Given this list of marker genes POLR2A, FUS, PPP1R8, NCBP1, CPSF7, SF3A2, SNRPC, SRSF4, POLR2K, SF3B3, RBM5, PABPN1, CSTF2T, PHF5A, UBB, SRSF2, HNRNPU, PAPOLA, SYMPK, SRSF9, RBMX, CSTF3, SF3B2, UBA52, POLR2D, SNRPD1, SUGP1, CHERP, SF3B1, SNRPA, TUT1, XRN2, FIP1L1, PPP1CA, CPSF2, SRSF1, HTATSF1, CLP1, HNRNPH2, PUF60, HNRNPA2B1, NCBP2, POLR2J, SRSF10, CPSF3, RBM10, SNRPF, POLR2F (RNA polymerase II, I and III subunit F), PCBP1, U2AF1L4, SRRT, DHX9, HNRNPA1, CDC40, PCBP2, SNRNP70, DDX42, POLR2C, CCAR1, PAPOLG, SNRPD2, POLR2L, SNRPB2, WDR33, PPP1CB, PCF11, SRSF6 (NCBI Gene Id 6431), SRSF5, SRSF12, DDX5, TCERG1, HNRNPD, SNRPD3, CSTF2, U2AF1, CPSF1, SNRPB, SRSF8, HNRNPC, HNRNPR, SNRPA1, RBM39, POLR2I, PRPF40A, U2AF2, POLR2G, SRSF11, GTF2F2 (NCBI Gene Id 2963), PPP1R10, HNRNPL (heterogeneous nuclear ribonucleoprotein L), CSTF1, RPS27A, SRSF7, HNRNPH1 (heterogeneous nuclear ribonucleoprotein H1), POLR2H, HNRNPF, NUDT21, RBBP6, GTF2F1, RBM25, SF3A3, SF3B6, SRRM2, DNAJC8, UBC, RBM17, U2SURP, SF3B4, SF3B5, HNRNPA3, SF3A1, CPSF4, HNRNPK, PTBP1, YBX1, POLR2E, HNRNPM, POLR2B, CPSF6, SNRPG, SMNDC1, SRSF3, TRA2B, SNRPE, SNRPN, DDX46, DHX15, here is a description of the gene set: studied in species Homo sapiens Reactome Pathway: mRNA Polyadenylation part of: mRNA 3'-end processing <p>All eukaryotic mRNAs, with the exception of histone mRNAs, undergo a 3' end maturation step consisting of a specific endonucleolytic cleavage of the precursor followed by polyadenylation of the upstream cleavage fragment; the downstream fragment is degraded. In mammalian cells, the pre-mRNA cleavage site is determined by at least four sequence elements. 1) The central and most highly conserved signal is AAUAAA or a close variant located ~20 nucleotides (nt) upstream of the cleavage site. 2) The preferred sequence at the cleavage site is CA. 3) GU- or G-rich downstream elements are important, and 4) sequences upstream of AAUAAA, such as UGUA, can also contribute. The majority of protein-coding genes have multiple polyadenylation sites (PASs) generating either different protein isoforms or mRNA isoforms differing in the lengths of their 3' untranslated regions (UTRs) and consequently in their interaction with RNA-binding proteins and microRNAs. Formation of mRNA isoforms through differential usage of PASs is called alternative polyadenylation (APA). APA is frequently used in all eukaryotes, and more than 70% of protein-coding mRNAs in mammals are subject to APA.</p><p>In mammalian cells, more than twenty core proteins organized into several different complexes are dedicated to the cleavage and polyadenylation (CP) reaction. A much larger set of ~80 proteins has been identified by affinity purification of a mammalian 3' processing complex and mass spectrometric analysis. Some of these proteins may contribute to the coupling of 3' processing to transcription and other processes. The central complex is the cleavage and polyadenylation specificity factor (CPSF). CPSF carries the catalytic activity for pre-mRNA cleavage, and its interaction with the AAUAAA sequence is essential for cleavage and the AAUAAA dependence of polyadenylation. The CPSF complex is thought to consist of seven proteins: CPSF1 (CPSF160), CPSF2 (CPSF100), CPSF3 (CPSF73), CPSF4 (CPSF30), FIP1L1 (FIP1), WDR33, and SYMPK (Symplekin). SYMPK is considered to be a scaffolding factor, as it interacts with both the CPSF complex and the CSTF complex. The cleavage stimulation factor (CSTF) complex has three different subunits, CSTF1, CSTF2 and CSTF3, and recognizes downstream elements. The cleavage factor I (CF I) complex recognizes the UGUA upstream element. The CF I complex is a heterotetramer consisting of a homodimer of NUDT21 (CPSF5) and a homo- or a heterodimer of CPSF6 and CPSF7. The cleavage factor II (CF II) complex is a heterodimer of two subunits, CLP1 and PCF11. The function of CF II is poorly studied. It has been proposed that CF II contributes to the recognition of cleavage/polyadenylation substrates through interaction with G-rich far-downstream sequence elements. The poly(A) polymerase generates the poly(A) tail and can also contribute to cleavage. Although CPSF and poly(A) polymerase are sufficient for AAUAAA-dependent polyadenylation, the nuclear poly(A)-binding protein 1 (PABPN1) stimulates poly(A) tail extension and is essential for the synthesis of a poly(A) tail of the appropriate length. Three related RNA poly(A) polymerases exist in mammals, PAPOLA, PAPOLB and PAPOLG. PAPOLA, also known as PAP or poly(A) polymerase alpha or PAPII, is considered to be the canonical poly(A) polymerase in mRNA polyadenylation. PAPOLG, commonly known as poly(A) polymerase gamma, localizes to the nucleus like PAPOLA, and co-immunoprecipitates with the 3' processing complex. PAPOLG shares 60% identity to human PAPOLA at the amino acid level. PAPOLG exhibits fundamental properties of a bona fide poly(A) polymerase, specificity for ATP, and CPSF/AAUAAA-dependent polyadenylation activity. The catalytic parameters indicate similar catalytic efficiency to that of PAPOLA. PAPOLG and PAPOLA have similar organization of structural and functional domains. PAPOLG contains a U1A protein-interacting region in its C terminus, and PAPOLG activity can be inhibited, as PAPOLA, by the U1A protein. PAPOLG may also function in monoadenylation of small RNAs. PAPOLB, also known as TPAP or poly(A) polymerase beta, is a cytosolic poly(A) polymerase specifically expressed in the testis. PAPOLB is thought to govern germ cell morphogenesis by modulating specific transcription factors at posttranscriptional and posttranslational levels. An additional nuclear poly(A) polymerase in mammals is TUT1 (also known as STAR-PAP or STPAP), which preferentially polyadenylates pre-mRNAs of oxidative stress-induced genes.</p>